Given this list of marker genes Smyd3, Hira, Mcm2, Smarca5, H2ac25, H1f2, Tspyl1, Sox9, Brd2, H1f8, Setd2 (NCBI Gene Id 70927), Macroh2a2, Sart3, H3f3c, Chaf1a (chromatin assembly factor 1, subunit A), Npm1, Mcm3ap, Tspyl5, Smarce1, Chrac1, Smarcc2 (SWI/SNF related, matrix associated, actin dependent regulator of chromatin, subfamily c, member 2), Naa60, Padi4, Grwd1, H1f9, Smarca4, Chaf1b, Smarcd2, Hp1bp3, Atrx, Ttc39aos1, Nap1l3, Chd2, Daxx, Spty2d1, Smarcc1, H1f5, Asf1a, Kat6b, Smarcb1 (NCBI Gene Id 20587), Kat6a (NCBI Gene Id 60407), Supt6, Nap1l1, Anp32b, Arid2, Shprh, Atad2, Arid1a (NCBI Gene Id 93760), Asf1b, Set (SET nuclear oncogene), Smarca2, Lin54, Supt16, H1f3, H2al2a, H2bc1, Dnajc9, Chd1, Ubn1, Tspyl4, H1f6, Smarcd3, Nasp, H4c14, Nap1l4, Nap1l2, H1f1, Cebpg, Nap1l5, Baz1a, Atad2b, Macroh2a1, H1f4, Rbbp4, Pole3, Tnp1, Smarcd1, Tspyl2, Ssrp1, Rsf1, H1f0, here is a description of the gene set: studied in species Mus musculus Mouse Gene Set: GOBP_NUCLEOSOME_ORGANIZATION A process that is carried out at the cellular level which results in the assembly, arrangement of constituent parts, or disassembly of one or more nucleosomes.